Given this list of marker genes SELENOS (selenoprotein S), SLC26A6 (solute carrier family 26 member 6), PRKCE, ANO1, FBP1, COL6A2, EIF2B5, EIF2B4, AGER, GRIA1, GJD3, MIR320D1 (NCBI Gene Id 100313896), PCK2, HNF1B, SESN2, IRS2, SMAD4, RFX6, SRF, RAP1A, UCP2, GPX1, SREBF1, FIS1, VSNL1, RPTOR, NKX2-2, PFKFB2, ACVR2B, SERPINF1, GCKR, GPR68, MIR320C2, ACVR1C, PTPRN2, PRKCB, CLTRN, PDE8B, EIF2B3, KAT7, ADCY5, HID1 (NCBI Gene Id 80791), KCNK16, GUCA2B, LYN, BRSK2, PIM3, PRKAA1, ADRA2A, XBP1, EFNA5, PPARA, RMI1, MIR320D2, GIP, TRPA1 (NCBI Gene Id 8989), SRI, C1QTNF12, GATA4, CFTR, COLEC12, NADK, PLA2G6 (phospholipase A2 group VI), IL1B, SGCB, KHK, G6PC1, SOD2, OXCT1, PIK3CA, OXT, GCG, PRLH, KLF7, CRH, NR1H4, GCLM (glutamate-cysteine ligase modifier subunit), CCDC186, PRKAA2 (protein kinase AMP-activated catalytic subunit alpha 2), LIN28A, BAIAP3, MIR221, HNF4A, CYP7A1, MIR320A, ADNP, APOA2, LPL, MIR15A, NPTX1, CDT1, VAMP2 (vesicle associated membrane protein 2), FOXO3, P2RX2, GPAM, SELENOT, SMARCB1, GHRL, PCK1, MAFA, ZBED3, GIPR, GPR82, USF1, PDX1, EIF2B2, ANGPT2, PPARD, GJB6, SMAD2, COL6A3, SYBU, IGF1R, MAPK13, OGT, RAC1, MAP2K3, PRKN, NKX6-1, NDUFAF2, ENDOG, PFKL, UNC13B, MIR320E, HIF1A, EXTL3, FKBP1B, KAT5, NAGLU, DYNLL1, TNF, SMARCA4, LEP, ERN1, MIRLET7G, SLC12A7, MIR320C1, RAB11FIP2, MLXIPL, REG3A, RASAL2, BAD, RPS6KA2, GAS6, SLC39A14, TUNAR, MIR320B2, ABCC8, NOX4, KCNB1, NEUROD1, SLC29A1, ENY2, TRPM5, OPRK1, LRP5, NR1D1, GOT1, NR0B2, RAB11FIP5, EGR1, CYBA, THBS1, STX4, PKLR, MPC2, NCF1, MIR16-1, EIF2B1, PAX2, USF2, MIR146A (NCBI Gene Id 406938), FAM3A, CALCRL, TRPM4, PHPT1, ILDR2, GYS2, STXBP4, SIN3A, GPLD1, CDK16, TGFB1, UCN3, RACK1, MIR320B1, SLC30A8, CAT, PTPRN, PRKACA, SMAD3, PNPLA3, FOXA2, GLUL, TCF7L2, SLC2A2, SIDT2, RAF1, JAGN1, ABCA12, PIH1D1, SLC2A5, ADIPOQ, ITGA2, RBM4, MIR337, TXNIP, COL1A1, GPR27, GCLC, CLEC7A (C-type lectin domain containing 7A), TRA2B, ZNF236, GCK, FUT1, GSTP1, ZBTB20, PLCB1, HMGCS2, GHRHR, PPP3CB, P2RX3, ZFP36L1, TREM2, CASP3, ME1, EPHA5, HLA-DRB1, ICAM1, ADCY8, ELAVL1, OSBP, GPER1, LCN2, IGF1, SARM1, UBTF, C2CD2L, GPRC6A (G protein-coupled receptor class C group 6 member A), CASR, MAP1B, CMA1, SLC9B2, SOX4, RAB11B, ZBED6, SLC12A6, here is a description of the gene set: species: Homo sapiens Human Gene Set: GOBP_RESPONSE_TO_CARBOHYDRATE Any process that results in a change in state or activity of a cell or an organism (in terms of movement, secretion, enzyme production, gene expression, etc.) as a result of a carbohydrate stimulus.